Given this list of marker genes NUP107, NUP35, NUP54, NP, NUP85, AAAS, NUP93, PA, PB2, TPR (NCBI Gene Id 7175), NS, NDC1, RANBP2, NUP37, SEH1L, PB1, NUP160, NUP214, NUP155, NUP58, M, NUP210, NUP42, RAN, SEC13, NUP43, NUP205, XPO1, NUP153 (NCBI Gene Id 9972), POM121C, NUP98, NUP188, RAE1 (NCBI Gene Id 8480), POM121, NUP133, NUP88 (NCBI Gene Id 4927), NUP50, NUP62, here is a description of the gene set: The viral RNP complex is exported from the nucleus via the host cell CRM1 export pathway. The vRNP complex does not interact directly with CRM1 to form an export complex. Rather, an additional viral protein, nuclear export protein (NEP/NS2), acts as an adaptor, binding the viral matrix M1 protein and CRM1, thus linking the viral RNP with CRM1. The CRM1/exportin-1 complex recruits additional host cell proteins, and traverses the nuclear pore into the cytosol. part of: Export of Viral Ribonucleoproteins from Nucleus species: Homo sapiens Reactome Pathway: NEP/NS2 Interacts with the Cellular Export Machinery